Given this list of marker genes VAMP5, CASKIN2, KSR1, UBE2M, GNG2, MPP2, ZDHHC2, TFRC, MARCKSL1, ATP6V1H (ATPase H+ transporting V1 subunit H), UAP1L1 (UDP-N-acetylglucosamine pyrophosphorylase 1 like 1), MYDGF, SYNGR2, UFC1, PKP4, VRK1 (VRK serine/threonine kinase 1), ASAP1, GNA14, CD38, PGK1, SH3GL3, UCP2, TBC1D4, PRR13, COPE, VMP1, SLC11A2, DCXR, BBLN, HMOX1, BATF, RRP7A, LONRF1, RAB19, IPMK, PTPN11, UBE2I, LIG1 (DNA ligase 1), GLA (galactosidase alpha), ADAP1, SH3RF1, SEPTIN9, MAPKAP1, CDK6 (NCBI Gene Id 1021), S100A11, SAR1B, SRGN, ATF6, CCR4, ANXA4, MAN2B2, HIGD1C, LUZP1, PHF6, RNH1, GRHL1, MPZL3, CASP4, DDT, PLCL1, NFATC1 (nuclear factor of activated T cells 1), TOMM40L, RAPH1, FYN, EHD3, SLC25A19, ABCB1, PANK1 (NCBI Gene Id 53354), ARHGAP21, ST3GAL1 (NCBI Gene Id 6482), MTHFD2, UBE2V1, CEP15, UNC119, SPCS3, ALDOC, MYO1C, CD83, PGAM1, PDCD1LG2, CEBPZOS, PRPS2 (phosphoribosyl pyrophosphate synthetase 2), PDE6D, LCLAT1, OAS1, HIKESHI, ARHGAP31, CYB561, DYNLRB1, EI24, CARD14, GNG3, TRIM35, PPP2R5C, TNFAIP8, DNAJC1, KPTN, GPT2, STX11 (syntaxin 11), PLEKHO2, CD200 (NCBI Gene Id 4345), PBX3, DNAJB11, PPFIBP1, EBI3, FAM156A, IDE, FKBP1A, CSK, CBX6, GSKIP (GSK3B interacting protein), ZNHIT1, KCTD17, SNRNP25, FAM162A, LAMP2, KCTD9, ARPC3, EFHD2, CD2BP2 (NCBI Gene Id 10421), CD22, GADD45B, SLAMF6, OSTC, FAM241B (NCBI Gene Id 219738), TMEM167A, GLOD4, SH2D1A, SCRN3, HMCES, PTGER2, SLC25A13, ZMAT5, LIME1, H1-0, EGR1, COLCA1, BCL6, DNAJC24, SOX30, FAM216A, DESI1, PDIA3, IRAG2, LBH, ACOT7, GRAMD1B, CHSY1, POGLUT3, ENDOD1, HIVEP2, PSMD7, CARHSP1, FCRL1 (Fc receptor like 1), MPP1, MGAT5, TNC, NRP1, NABP2, CALHM2, MRPS6, POU2F3, GNG10, HES1, RNF157, SSR4, PHACTR2, NPAS2, SLC22A15, ZNF821, PLXNC1, TMEM86A, TNFSF11, CASP1, CD160, SLA, POU2AF1, SLC41A1, COX17, IL12RB1, SLC5A3, TNFSF8 (NCBI Gene Id 944), ITGB1, CCDC28B, TMEM101, SMTN, TXNDC17, OVOL1, ACYP2, ICAM4, YBX3 (Y-box binding protein 3), RABEPK, IL21, PTPN3, TOR2A, EVI2A, IKZF2, MAPRE2, PDLIM7, MAGED1, here is a description of the gene set: from publication Szatmari I, Pap A, Rühl R, Ma JX, Illarionov PA, Besra GS, Rajnavolgyi E, Dezso B, Nagy L (PMID 16982809) Genes up-regulated in monocyte-derived dendritic cells: rosiglitazone versus rosiglitazone and AM580. Human Gene Set: GSE5679_PPARG_LIGAND_ROSIGLITAZONE_VS_ROSIGLITAZONE_AND_RARA_AGONIST_AM580_TREATED_DC_UP Our data indicated that activation of the PPARg nuclear receptor induces a retinoid response in human dendritic cells. In order to assess the contribution of retinoid signaling to the PPARg response we decided to use a combination of pharmacological activators and inhibitors of these pathways. Cells were treated with the synthetic PPARg ligand rosiglitazone (RSG), or with RSG along with the RARa antagonist (AGN193109) to block RARa mediated gene expression, or the RARa specific agonists (AM580) alone. This design allows one to determine if retinoid signaling is a downstream event of PPARg activation and what portion of PPARg regulated genes are regulated via induced retinoid signaling. species: Homo sapiens